Given this list of marker genes SNRPC, SRSF3, PRPF40B, RNVU1-4, SART1, SRSF7, RNVU1-8, RNVU1-2A, DDX23, WBP4, PRP4K, C9orf78, SRSF1, PSIP1, RNVU1-1, NCBP2L, RNVU1-19, SNRNP200, EXOSC10, UPF3A, TAF12-DT, RNVU1-15, RNU11, UPF3B, UPF1, CACTIN, RNVU1-17, RNU6ATAC, PRPF40A, RNU1-4, RNVU1-7, RNVU1-14, RNVU1-6, RNVU1-3, RNU4ATAC, RBM22, CLNS1A, SF3A1, WEE2-AS1, NCBP2, PRPF39, DCPS, RBM17, SFSWAP (NCBI Gene Id 6433), SDE2, SRSF12, CWC15, here is a description of the gene set: The joining together, after removal of an intervening sequence composed of one or more introns, of two segments of the same RNA molecule via spliceosomal catalysis to produce an mRNA composed only of exon sequences that all came from the same primary transcript. Human Gene Set: GOBP_MRNA_CIS_SPLICING_VIA_SPLICEOSOME studied in species Homo sapiens